Given this list of marker genes ITGA6, PDE1A, TM4SF18, APOD (NCBI Gene Id 347, apolipoprotein D), CALM1, FOXL2, SVIL (NCBI Gene Id 6840), PEG10, CAVIN1, LUM, VWF, MMRN2, SERPINE2, MECOM, HLA-E, SMOC2, MXRA8, COL6A1, MYLK (NCBI Gene Id 50483), COL1A1 (NCBI Gene Id 4970), IGFBP2, ISYNA1, PDGFRA, CDH11, B2M, CLSTN2, ISLR, HLA-B, COL12A1 (NCBI Gene Id 1304), NBL1, LBH, ACSM3, FBLN1, SPARCL1, MDK (NCBI Gene Id 4192), CMYA5, LTBP4, ITM2A, COL14A1, SOX18, FXYD1, RRAD, GIMAP7, MFAP4, TIMP3, GNG11, SLC7A2, C7, C1R, SNRK, MFGE8, SCD5, C1S, FAM43A, HLA-F (NCBI Gene Id 3134), CRIM1, TINAGL1, ROBO4, CCDC80, ETS1, CD34, TBX2-AS1, IGFBP5, NOSTRIN, CRIP2, COL6A3, ADIRF, CFH, LRRC17, FGF7, ABLIM1, CRIP1, ADGRL4, EFNA1, DOCK9, DCN, TBX2, DSTN, PTP4A3, CLEC14A, EPB41L4A-AS1, EPAS1, ABCA8, ITGA1, AEBP1, SNHG32, LIFR, HLA-C, MYCT1, MCAM, SGCE, here is a description of the gene set: from publication Jones ASK, Hannum DF, Machlin JH, Tan A, Ma Q, Ulrich ND, Shen YC, Ciarelli M, Padmanabhan V, Marsh EE, Hammoud S, Li JZ, Shikanov A (PMID 38578993) The reproductive and endocrine functions of the ovary involve spatially defined interactions among specialized cell populations. Despite the ovary's importance in fertility and endocrine health, functional attributes of ovarian cells are largely uncharacterized. Here, we profiled >genes in 257 regions from the ovaries of two premenopausal donors to examine the functional units in the ovary. We also generated single-cell RNA sequencing data for 21,198 cells from three additional donors and identified four major cell types and four immune cell subtypes. Custom selection of sampling areas revealed distinct gene activities for oocytes, theca, and granulosa cells. These data contributed panels of oocyte-, theca-, and granulosa-specific genes, thus expanding the knowledge of molecular programs driving follicle development. Serial samples around oocytes and across the cortex and medulla uncovered previously unappreciated variation of hormone and extracellular matrix remodeling activities. This combined spatial and single-cell atlas serves as a resource for future studies of rare cells and pathological states in the ovary. Marker genes selected by filtering the centroid data for genes with a value > 0 for the given cell type species: Homo sapiens Human Gene Set: JONES_OVARY_T_CELL